Given this list of marker genes SMYD5, ISG20, EYA2, DNAJC2, CEBPB, MFNG, HSPA5, CCR1, ELOVL6, HNRNPAB, IQGAP2, NUP210, UBE2J1, MAGOHB, IL2RG, RAN, TNS3, SET, FERMT1, APOBEC3B, CBS, TNFRSF10D, SLC19A1, EMC1, PPFIBP1, CUL1, HSPA1A, HBB, EIF5, SRSF7, CBX4, PSPH, LARP1, HDGF, PAK1IP1, TNFRSF17, MYL2, HGF, WIPF1, LSAMP, OLAH, DNAJB4, ZBTB38, CD28, GALNT14, CLIC2, ATF3, CCN4, PLA2G4B, OGT, MBP, LY9, CAPN2, TMPRSS15, ZMYND8 (zinc finger MYND-type containing 8), CLEC7A, TRIB3, SLA, PFKP, PPP1R16B, DOCK10 (NCBI Gene Id 9714), WNT5B, CD44, AIM2, IRAK1, LIMD2, MED17, FLI1, SLC7A5, CLEC2B, ZNF532, SHMT2, MAF, ERAP1, RRP15 (ribosomal RNA processing 15 homolog), PLK1, CRLF2, PNO1, HSPE1, MYOM2, MAP4K1, LRRC41, SDC1, RRS1, SH2D1A (NCBI Gene Id 4068), HOMER3, ITGB7, CYTIP, MYB, KLHL21, NMU, MGAT3, PPRC1, PPIF, SLC1A4, CNTN6, HBG1, CDK5R1, CD52, IGKC, CD180, CCND2, TCF4, DNAJC15, MYBL2, STAG2, HLA-DRA, GTSE1, HSPA9, P2RX5, GADD45A, NOP14, MYCN, SULF1, CLK1, CHAC1, VARS1, NOL12, DCC, XBP1, GBA1, ATF4, LY96 (lymphocyte antigen 96), GTF3A, QPCT, DCPS, TIMM44, LRP8, CCDC69, CCR2 (NCBI Gene Id 90262), SIK1, TMEM255A, KCNT2, DDX17, KCNK1, CDKN1B, CADM1, PHACTR2, LAPTM5, UCK2, CRELD2, PPP1R15A, DFFB, PDIA3, FAS, CFLAR, SLC3A2, INHBE (inhibin subunit beta E), NMRK2, PUS1, PSAT1, KANK1, AUTS2, PATZ1, CELF2, NFE2L1, HSPH1, PDIA4 (protein disulfide isomerase family A member 4), SETBP1, CTPS1, SLC47A1, ELAC2, HERPUD1, HSPD1, MAGEH1, DEPTOR, GSTO1, CCPG1, CNIH3, LRRC61, ELF1, HSP90B1, ZHX2, CTSC, SFPQ, ARHGDIB, CHST15, FKBP4, CTSH, TPP1, TAPBPL, FMNL1, ADI1, SORD, TMED1, EMP3, ST3GAL6, ABCE1, PDZK1, KCNN3, DESI2, PKD1, TTC39A, ECPAS, SNTB1, HBD, EHD3, RIPOR2, DNAJB9, UBE2E1, ADCY7, BAG3, EIF5A, AVEN, OSBPL1A, ST6GAL1, FABP5, ZEB2, SLC7A11, PITPNC1, PTPRC, ST7, S100A11, PDE4D, TLK1, RUBCNL, CCND1, CD48, NOP56, CTBP2, CTH, NSMAF (NCBI Gene Id 8439), SERPINH1, FAM149A, MRTO4 (MRT4 homolog, ribosome maturation factor), KIAA1549L, RASGRP3, MAPK13, GJA1, CEBPG (NCBI Gene Id 1054), BCL2, TSHR, DUSP6, SLC6A15, TRAF3IP3, NUDT1, DNAJB1, ITGB5, MYCL, SLC33A1, PMAIP1, APOBEC3G, IRAG2, PRTN3, POU2AF1, RPS19, CALR, OLR1 (oxidized low density lipoprotein receptor 1), TMPRSS3, PHF11, ZMIZ1, SSX4, ABHD14A, BLNK, SOX11, SELPLG, GUCY1A1, SLC38A1, IL6R, ERO1B, ADCYAP1, NOP16, MYC, SUMO3, ANK3 (NCBI Gene Id 288), HSPA1B, ATIC, GPM6B, IL21R, TYMS, RORA, CEACAM1, INPP5D, GAS2, SERP1, MRPL3, RHOH, AK1, DDIT3, SLC16A6, HMOX1, TRBV21-1, PSMB10, SEC24D, HSPA6, EIF4G2 (NCBI Gene Id 1982), BCL2L1, FAIM, NSD2, NFIC, MAFF, FGFR3, PBX1, here is a description of the gene set: from publication Heller G, Schmidt WM, Ziegler B, Holzer S, Müllauer L, Bilban M, Zielinski CC, Drach J, Zöchbauer-Müller S (PMID 18172295) Human Gene Set: HELLER_HDAC_TARGETS_DN Genes down-regulated in at least one of three multiple myeloma (MM) cell lines by TSA. To identify epigenetically silenced cancer-related genes and to determine molecular effects of 5-aza-2'-deoxycytidine (Aza-dC) and/or trichostatin A (TSA) in multiple myeloma (MM), we analyzed global changes in gene expression profiles of three MM cell lines by microarray analysis. We identified up-regulation of several genes whose epigenetic silencing in MM is well known. However, much more importantly, we identified a large number of epigenetically inactivated cancer-related genes that are involved in various physiologic processes and whose epigenetic regulation in MM was unknown thus far. In addition, drug treatment of MM cell lines resulted in down-regulation of several MM proliferation-associated factors (i.e., MAF, CCND1/2, MYC, FGFR3, MMSET). Ten Aza-dC and/or TSA up-regulated genes (CPEB1, CD9, GJA1, BCL7c, GADD45G, AKAP12, TFPI2, CCNA1, SPARC, and BNIP3) were selected for methylation analysis in six MM cell lines, 24 samples from patients with monoclonal gammopathy of undetermined significance (MGUS), and 111 samples from patients with MM. Methylation frequencies of these genes ranged between 0% and 17% in MGUS samples and between 5% and 50% in MM samples. Interestingly, methylation of SPARC and BNIP3 was statistically significantly associated with a poor overall survival of MM patients (P = 0.003 and P = 0.017, respectively). Moreover, SPARC methylation was associated with loss of SPARC protein expression by immunostaining in a subset of MM patients. In conclusion, we identified new targets for aberrant methylation in monoclonal gammopathies, and our results suggest that DNA methyltransferase and histone deacetylase inhibition might play an important role in the future treatment of patients with MM. species: Homo sapiens